Given this list of marker genes Zbtb7a, Ercc8, Lig4, Uvrag, Xrcc6, Topbp1, Bend2, Trp53bp1, Rnf168, Ercc6, here is a description of the gene set: An instance of double-strand break repair via nonhomologous end joining that requires a number of factors important for V(D)J recombination, including the KU70/80 heterodimer (KU), XRCC4, ligase IV, and DNA-PKcs in mammals. It does not produce translocations (as opposed to the alternative nonhomologous end joining). species: Mus musculus Mouse Gene Set: GOBP_DOUBLE_STRAND_BREAK_REPAIR_VIA_CLASSICAL_NONHOMOLOGOUS_END_JOINING